Given this list of marker genes Apaf1, Dffb, Hsf1, Dffa, Endog, Atm, Rgn, Cidea, Aifm1, Bax, Nmnat1, Cdkn2a, Il6, Gata5, Igfbp3, here is a description of the gene set: Any process that modulates the frequency, rate or extent of DNA catabolic process. studied in species Mus musculus Mouse Gene Set: GOBP_REGULATION_OF_DNA_CATABOLIC_PROCESS